The following is a description of a gene set: CD4 T follicular helper (Tfh) cells provide the required signals to B cells for germinal center reactions that are necessary for longlived antibody responses. However, it remains unclear whether there are CD4+ memory T cells committed to the Tfh lineage after antigen clearance. Using adoptive transfer of antigen-specific memory CD4+ subpopulations (based on CXCR5 and Ly6c expression)in the LCMV infection model, we found that there are distinct memory CD4+ T cell populations with commitment to the Tfh and Th1 lineages. Our conclusions are based on gene expression profiles, epigenetic studies and phenotypic and functional analysis. The gene expression profiles of virus-specific CD4 T cell subets at effector and memory stages is presented here. from publication Hale JS, Youngblood B, Latner DR, Mohammed AU, Ye L, Akondy RS, Wu T, Iyer SS, Ahmed R (PMID 23583644) Genes up-regulated in CD4 SMARTA T cells: naïve versus effector during acute infection of LCMV. species: Homo sapiens Human Gene Set: GSE43863_NAIVE_VS_TFH_CD4_EFF_TCELL_D6_LCMV_UP, and this is the list of marker genes: PKM, PREX1, MEDAG, RALYL, MANF, HBEGF, CDK14, PWP1, LARS1, SPIC, GORASP2, HTR2B, RNF19A, ITFG2, FAM118B, BRD1, FILIP1L, HOXD1, SLC20A2, LRRC8A (leucine rich repeat containing 8 VRAC subunit A), CPSF2, ABHD2, LMO2, MAPKAP1, FDPS, PTPRE, CIDEB, POP1, SNHG16, SLC7A6, SCAP, BAZ2B-AS1, YWHAZ, POLR1A, ETF1, HOXA11, UTP25, ANP32A, C19orf53, HSPB1, SERP1, MEX3A, B4GALT2, RER1, WASF3, CCNI, DCTD, SLC35A2, SH2D3C, FAM168B, PPP1R18, TMEM68 (NCBI Gene Id 137695), TUG1, CNST, PBX1, PFKM, SLC38A2, ELP1, SMAD6, IGFBP2, GID8, SQLE, TNFRSF10D, SRXN1, ATP5F1A, ELN, MTERF4, DSTN, NONO, TGFB2, KAT7 (lysine acetyltransferase 7), NSMCE3, RARS2 (NCBI Gene Id 91066), VMP1, NT5DC2, NUBP2, DAB2, MLX, IFNA4, NOB1, EIF6, GALNT1, ZNF254, CPNE1, TRMT13, TACSTD2, MPI, RNASE1, UBC, SOCS2, UBA5, FLNB, FLRT2, SRP68, ALDH6A1, ADAM15, CCDC144NL-AS1, ATP5F1B, POC5, VIRMA, STIM2, CUL4A, CNTRL, RPP14, MEST, ITGA5 (NCBI Gene Id 3678), EEF1G (NCBI Gene Id 1937), GRPEL1, ATF7, TCTN1, ANKRD50, USH2A, SSR2, HSPA9, ATG7, ZNF652, MMP10, MAPK14, ACO2, ITGA2, PRKAG1, PRCP, ID1, RHOC, RFWD3, GJA5, TLN1, FAM114A1, GABPB1-AS1, DHX35, TCEANC2, CAD, CRIP2, CREB3L2, LRRC42, NEU1, LIMS3, FEM1A, FAM124B, ALPK3, TSPAN13, PUDP, LINC01013, UBE3C, TNFRSF12A, TUBB, AADACP1, KCTD1, MBTD1, LPP-AS2, HHIP, ABI2, MECR, PXDC1, CCND2, ATP2A2, EGR1, PPP1R14B, CDC25A, NDRG4, APEX1, GPR176, YIPF2, DUSP1, SHE, NOP16, DPY19L1, RBM15B, RPGR, TPR, S100A4, PRKCE, ADAT1, ZNF692, SIRT7, HHAT, FLNA, DIPK1A, TRAPPC1, KIF3B, MS4A5, RHOJ, IFT172, NRG3, GALNT2 (polypeptide N-acetylgalactosaminyltransferase 2), IL24, EMP1, FZD4, CD99, RRAS, LRRC8D, LDB2, SNX17, HSPA8 (NCBI Gene Id 3312), CERS2, SELENOS, TWIST1